Given this list of marker genes MLIP, DHH, JAG2, HNRNPA2B1, ATXN3 (NCBI Gene Id 4287), MTMR2, CACNA1A, HINT1 (NCBI Gene Id 3094), PHKA1, PRRT2, DARS2, DNM2, PPP1R15B, PTRH2, SPTBN4 (spectrin beta, non-erythrocytic 4), HMBS, CADM3, PLEC, MAPT, TOR1AIP1, AIFM1, DUX4L1, HNRNPA1, ATP7A, TBK1, MORC2, ALG2, PNPLA6, GMPPB, GFPT1, HSPB1, MFN2, VWA1, ALG14, NEB, TCAP, SH3TC2, HK1, RAI1 (retinoic acid induced 1), GTPBP2, AFG3L2, MTMR14, ZFTA, ADSS1 (adenylosuccinate synthase 1), JPH1, REEP1, WARS1, SYT2, DPAGT1, FLVCR1, HSPB3, IMPDH2, DYSF, GJB1, MTTP, PEX7, ANG, GBF1, DHTKD1, ISCU, MYH7, TARDBP, PRX, NAGA, C19orf12, ATP1A1, DNMT3B, MYH14, LMNA, MYBPC1, NEFL, SACS, PMP2, DGUOK, TRMT10A, TYMP, GIPC1, ALS2, DNMT1, TRPV4, VPS13A, CPT1C, MT-ATP6, SETX, RRM2B, CLCN1, CPOX, TNPO3, MCM3AP, GARS1 (glycyl-tRNA synthetase 1), ATL1, RFC1, RYR1, SIGMAR1, SPTLC2, CHP1, ITPR3, BICD2, MYMK, FIG4, COL6A3, FRG1, LAMP2 (NCBI Gene Id 3920), MED25, VHL, VAPB, YARS1, COL6A2, SLC25A19, PLIN4, FLNC, CAV3, SPTLC1, UBA1, TK2, SPG11, IBA57, NOTCH2NLC, PLEKHG5, SQSTM1, HADHB, LAMB2, VRK1, DDHD2, VPS13D, MME, BIN1, SMCHD1, TDP1, COL12A1, SNAP25, FUS, DYNC1H1, ANO5, ATXN1, FGD4 (NCBI Gene Id 619403), SCYL1 (NCBI Gene Id 57410), EMILIN1, MATR3, LIG3, LRP12, ALDH18A1, ABHD16A, PNPLA2, ACTA1, SLC18A3, COL6A1, MPV17, PABPN1, EGR2, POLG, GAN, DES, ACTN2, DNAJB2, MPZ, PNKP, NUTM2B-AS1, MARS1, MAP3K20, DCTN1, LRSAM1 (leucine rich repeat and sterile alpha motif containing 1), AARS1, DUX4, XRCC1, PMP22, SMPX, MYO9A, RTN2, SLC12A6, SARDH, CCND1, PRPS1, ERLIN2, TIA1, ABCA1, ATP1A2, VAMP1, RAB7A, COA7, ABCD1, GDAP1, MYH2, ELOVL5, FKTN, GRIA3, FBLN5, CHAT, LDB3, KIF1A, MYOT, SLC25A1, SBF2, JAG1, SNUPN, GCH1, HEXB, VCP, BSCL2 (NCBI Gene Id 84753), CHCHD10, GYG1, MTRFR (mitochondrial translation release factor in rescue), COL13A1, SLC25A21, NR4A2, COLQ, HSPB8, TNR, SLC5A6, SLC5A7, KLHL9, HARS1, SPTAN1, OBSCN, ATL3, AGRN, SECISBP2, NDRG1, KIF1B (kinesin family member 1B, NCBI Gene Id 57598), DCAF8, SORD (sorbitol dehydrogenase), LITAF, SBF1, RILPL1, TWNK, BAG3, ZC4H2, GNE, COQ7, SOX10, GNB4, EXTL3, HADHA, CRYAB, IGHMBP2, TTN, TPM3, INF2, SCN1A, here is a description of the gene set: Reduced strength of the musculature of the distal extremities. species: Homo sapiens Human Gene Set: HP_DISTAL_MUSCLE_WEAKNESS Distal muscle weakness